The following is a description of a gene set: studied in species Homo sapiens A reduction below the normal concentration of a subclass of immunoglobulin G (IgG) in the blood. Decreased circulating IgG subclass concentration Human Gene Set: HP_DECREASED_CIRCULATING_IGG_SUBCLASS_CONCENTRATION, and this is the list of marker genes: PIK3CD, RNF113A, CD3G, CTPS1, EPG5 (ectopic P-granules 5 autophagy tethering factor), CD247, KMT2D, IFIH1 (interferon induced with helicase C domain 1), ATM, SH3KBP1 (SH3 domain containing kinase binding protein 1), KDM6A, CR2, ADA